Given this list of marker genes SLC38A2, SLC1A4, SLC36A4, SLC6A7, CLTRN, ACE2, SLC36A3 (solute carrier family 36 member 3), SLC6A20, SLC36A2, SLC7A8, SLC36A1, here is a description of the gene set: The directed movement of proline, pyrrolidine-2-carboxylic acid, across a membrane by means of some agent such as a transporter or pore. Human Gene Set: GOBP_PROLINE_TRANSMEMBRANE_TRANSPORT species: Homo sapiens